Given this list of marker genes IL1A, TNF, GDNF, CSF3, CCL15, CXCL8, IL11, IL3, CCL7, CCL18, CSF1, CCL5, EGF, here is a description of the gene set: studied in species Homo sapiens A molecular test for Alzheimer's disease could lead to better treatment and therapies. We found 18 signaling proteins in blood plasma that can be used to classify blinded samples from Alzheimer's and control subjects with close to 90% accuracy and to identify patients who had mild cognitive impairment that progressed to Alzheimer's disease 2-6 years later. Biological analysis of the 18 proteins points to systemic dysregulation of hematopoiesis, immune responses, apoptosis and neuronal support in presymptomatic Alzheimer's disease. from publication Ray S, Britschgi M, Herbert C, Takeda-Uchimura Y, Boxer A, Blennow K, Friedman LF, Galasko DR, Jutel M, Karydas A, Kaye JA, Leszek J, Miller BL, Minthon L, Quinn JF, Rabinovici GD, Robinson WH, Sabbagh MN, So YT, Sparks DL, Tabaton M, Tinklenberg J, Yesavage JA, Tibshirani R, Wyss-Coray T (PMID 17934472) A biomarker of plasma signaling proteins that predicts clinical Alzheimer's diagnosis. Human Gene Set: RAY_ALZHEIMERS_DISEASE